The following is a description of a gene set: Mouse Gene Set: REACTOME_RET_SIGNALING RET signaling studied in species Mus musculus, and this is the list of marker genes: Gfra3 (NCBI Gene Id 98132), Gfra1, Grb7, Pdlim7, Pik3r2 (NCBI Gene Id 18709), Pik3cb, Gab1, Grb2, Prkaca, Mapk7, Pik3r1, Shc3 (src homology 2 domain-containing transforming protein C3), Rap1gap, Irs2, Dok6, Frs2, Gfra4, Grb10, Prkacb, Gfra2, Shank3 (NCBI Gene Id 58234), Src, Artn, Dok4, Pik3r3, Dok5, Plcg1, Ret, Dok1 (NCBI Gene Id 13448), Ptpn11, Pik3ca, Pik3cd, Pspn, Shc1, Dok2, Nrtn, Sos1, Gdnf